Given this list of marker genes Dpm1, Pigm, Pigv, Dpm2, Dpm3, Pomt1, here is a description of the gene set: Mouse Gene Set: GOCC_MANNOSYLTRANSFERASE_COMPLEX studied in species Mus musculus A complex that possesses mannosyltransferase activity.